Given this list of marker genes CDH7, GAP43, LMBR1, CYP51A1, CEACAM5, TMEM17, HMMR, GGH, TPSB2, MAPK13, NHLRC1, TCF4, CDC6, CIT, UBA2, GMDS, PDIK1L, DES (desmin), SPRY4, COLGALT2, NAT1, TSNAXIP1, FMO1, UCMA, RAP2A, CSE1L, CCNG1, NAF1, KLHL23, CEP76 (NCBI Gene Id 79959), TMEM229A, DARS1, CCDC112, MIR451A, MBOAT2 (membrane bound O-acyltransferase domain containing 2), GNA15, CLPX, PMAIP1, FIGNL1, CPNE2, MLPH, FAM43A, NUP160, NAA50, PLXNB2, PLP1, TPD52, DUSP21, SDC4, HFE, DENND6B (NCBI Gene Id 414918), GNG11, PLK4, TBX5, PERP, PLA2G2D, FUS, PANK1, CCZ1 (NCBI Gene Id 51622), ATP10A, GRXCR1, SHROOM3, MIR17, MYH4, SPINK6, MRPL57 (NCBI Gene Id 84533), RAP1A, CENPI, KLF12, TSPAN6, MYOF, CHST1, TBC1D24, PIK3C2G, C1QL4, NF2, MCM8, RAD54L, THSD1, SOX13, ADGRG5 (adhesion G protein-coupled receptor G5), DSCC1, MYADM, UBAP2, PPAT, FRMD5, MIS18BP1, DRD2, NBEA, CD14, FGF18 (NCBI Gene Id 8817), IDO1, NOL12, P4HA3, EGFR, BRCA1, TM4SF1, LGI2, FSCN1, ANXA10, INTS4, FKBP6, GSDME, ANLN, BARD1, SKIC3, CAPZA2 (NCBI Gene Id 830), KPNA2, TRIM37, IPO5, SPIRE1, RAD51B, CYP2R1, SPCS3, RNASEH2B, FATE1, ECPAS, USP1, HSD17B13, DCDC2, KPNA3, HLF, KNL1, NQO1, MIR148A, NUP155, ETV4, COX5B, MIR543, CKAP5, SMYD2, SCTR, ECT2, SLC35F1, KCTD14, PPM1E, CLSPN (claspin), SMC2, EMP2, DBF4, RBM15, IGFBP5, LRRFIP2, STT3A, CNOT9, RAB1A, here is a description of the gene set: species: Homo sapiens Genes down-regulated in control CD4 T cell versus those infected with HIV-1 viruses lacking Env and Nef. Human Gene Set: GSE12963_UNINF_VS_ENV_AND_NEF_DEFICIENT_HIV1_INF_CD4_TCELL_DN from publication Dabrowska A, Kim N, Aldovini A (PMID 19050264) The high mutation rate of HIV is linked to the generation of viruses expressing proteins with altered function whose impact on disease progression is unknown. We investigated the effects of HIV-1 viruses lacking Env, Vpr and Nef on CD4+ T cell gene expression using high-density DNA microarray analysis and functional assays.